The following is a description of a gene set: studied in species Homo sapiens Genes up-regulated in U2OS cells (osteosarcoma) upon knockdown of HDAC3 by RNAi. from publication Senese S, Zaragoza K, Minardi S, Muradore I, Ronzoni S, Passafaro A, Bernard L, Draetta GF, Alcalay M, Seiser C, Chiocca S (PMID 17470557) Human Gene Set: SENESE_HDAC3_TARGETS_UP Posttranslational modifications of core histones are central to the regulation of gene expression. Histone deacetylases (HDACs) repress transcription by deacetylating histones, and class I HDACs have a crucial role in mouse, Xenopus laevis, zebra fish, and Caenorhabditis elegans development. The role of individual class I HDACs in tumor cell proliferation was investigated using RNA interference-mediated protein knockdown. We show here that in the absence of HDAC1 cells can arrest either at the G(1) phase of the cell cycle or at the G(2)/M transition, resulting in the loss of mitotic cells, cell growth inhibition, and an increase in the percentage of apoptotic cells. On the contrary, HDAC2 knockdown showed no effect on cell proliferation unless we concurrently knocked down HDAC1. Using gene expression profiling analysis, we found that inactivation of HDAC1 affected the transcription of specific target genes involved in proliferation and apoptosis. Furthermore, HDAC2 downregulation did not cause significant changes compared to control cells, while inactivation of HDAC1, HDAC1 plus HDAC2, or HDAC3 resulted in more distinct clusters. Loss of these HDACs might impair cell cycle progression by affecting not only the transcription of specific target genes but also other biological processes. Our data support the idea that a drug targeting specific HDACs could be highly beneficial in the treatment of cancer., and this is the list of marker genes: KLF3 (KLF transcription factor 3), ZNF644, PAPOLA, PKIA, NAV3, SKIC3 (NCBI Gene Id 9652), INPP5A, ADAM19, NNMT, SINHCAF, KLRC1, DOCK4, PMAIP1, TALAM1, KHDRBS3 (NCBI Gene Id 10656), SHISA2, IDS, ITGA6, TGFBR1 (transforming growth factor beta receptor 1), PCDHB15, AADAC, CNTNAP3, IFI16, CXCL8, MAP3K2, STEAP3, DHX9, HHIP, TOP1, ESYT2, SYTL5, F2RL1, CPEB2, RAB35, BMAL2, KDM1B, ZBTB20, GGA2, YWHAZ, TNKS2, MMP1, LTBP2, EMP1, VAMP3, NR4A2, CREM, SERINC3, NMRAL2P, RBAK, SH3YL1, CPEB4, USP32, SCARB2, UEVLD, NFKB2, IL7R, TPP1, CLCN5 (chloride voltage-gated channel 5), XKR4, AGO2, CCL2, OASL, IL1RAP, SLFN5, UBE2F, USP53, FXR1, GPR176, GPHN, MEX3C, SPANXB1, SEC61A1, CXCL5, KBTBD2, TNIK, PDP1, ANTXR2, HTRA1, ZNF480, DLGAP1-AS2, MBNL2, SZRD1, BDP1, MMP9, STMN2, TUBA1A, CANT1, TNFRSF10B, PPFIBP1 (PPFIA binding protein 1), TFAM, DDX3X, CHRNA9, BTG1, USP16, OTUB2, MAP2, CXCL10, ZBTB38, ATP6V1A, E2F7, PHLDB2, GEMIN8, TGFBR2, PRDM1, STX16, FBXW11, ARL4C, VEGFC, CAMK2D, GSK3B, IFIT2, CD46, SETD5, TM9SF4, MALAT1, IQGAP1, ARHGDIA, WDR6, TNFSF15 (NCBI Gene Id 9966), EXOC5, TMEM30A, MOSPD1, PLEKHH2, TAOK1, ADAM10, ZNF92, EXTL3, KYNU, PGM2L1, NREP, SPRED1, PDLIM4, IGF2R, ERRFI1, MCL1, ANKRD46, ITGB3, PTPRR, STIP1, SOD2 (superoxide dismutase 2), PDGFC, AP1S3, GEM, IL1RAPL1 (NCBI Gene Id 4399), TM4SF18, HMGA2, IGF2BP3, MSC-AS1, CASK, SCD, ARHGAP5, RBM14 (RNA binding motif protein 14), PARP8, DPYSL3, BICD2, EFNA1, SNAP23, TSGA10, PPP3CA, MAPK14, CD55, SNHG16, ZNF451, BRCC3, AKT3, STING1, MCM4, EPRS1, TNFRSF11B, ANXA4, TEAD1, SNAPC3, MET, ASPH, CCND2, SLC7A1, IGFBP5, ACOX2, NBPF14, FMNL2, AFF4, TBC1D9, JMJD1C, NFKBIA, IQGAP2, DST, CUL4B, SLC6A15, TRPM4, SPP1, EFHD2, OLFM1, AP1AR, VPS25, MIR3142HG, EDIL3, ROBO4, TBC1D4, STK4, NEDD4L, AKR1C1, UBE2QL1, NCEH1, ROR1, NDRG4, MYO6, E2F5, PRR4, GFER, KLHL28 (kelch like family member 28), NAP1L1, SLC14A1, DCBLD1, CHD4, SLAIN2, HMGA1, CMTM7, LPIN1, KMT5AP1, SMARCC1, RDUR, HSF1, PI3, TMEM259, RGS4, SKP2, NEFL, MBNL1, HOXB6, KLF6, CXCL3, AKR1C3, TRIB1, FUS, FAS, CDKAL1, RNF19A, CALM3, PPP4R3A, PIP5K1A, CDKN1C, CTSB, ATP2B1, GRB10, PDK4, RSPO3, FOXC1, PIK3IP1, SPTBN1, KRT6B, ZNF317, RAB43, SFRP1, GFPT2, TMED2, RANBP2, TMEM158, RB1, UBASH3B, SCAMP1, SLC12A8 (solute carrier family 12 member 8), SAV1, GNG12, DNAJC13, MYO1B (NCBI Gene Id 92451), STYX, IFIT1 (NCBI Gene Id 8374), ABCC4, PLAU, TNFAIP3, SERPINE2, CCDC148, HDAC9, STX1A, LINC00161, NFAT5, ACTR2, ATP11B, NR6A1 (NCBI Gene Id 2649), PDE4B, FZD8, ZMAT3 (NCBI Gene Id 64393), MAPKAP1, NFKBIZ, SPANXA1 (NCBI Gene Id 93488), JAK1, GNG2, HSPA4, RHOB, OGDH, RAB8B, GCNA, ARL14, ASH1L, NUP58, EZR, AKT1S1, RBBP9, ESM1, LPXN, PMP22, PTPN11, BIRC3, WEE1, MIER3, HEATR1, ATF3, NEAT1, CCDC88A, NAMPT, SLC25A15, GCH1, HYCC1, WAC, IL6ST, ITGB8, NFYA, CEP170, ADAMTSL1, ENC1, SLC39A6, LINC00520, TLR4, PAPPA, GNA13, HAS2, CLDN12, MEAK7, CEP120, OPN3, ARSJ, USP10, MAML3, FAT3, ZNF41, IGKV1OR1-1, SUPT16H, PRKACB, KITLG, EIF4G1 (eukaryotic translation initiation factor 4 gamma 1), ARFIP1, STK10, SPIRE1, ZNF697, ENSG00000254531, DUS3L, TRIO, GTF2I, SCYL2, HNMT, SMG7, FAM9B, TAB3 (TGF-beta activated kinase 1 (MAP3K7) binding protein 3), AP1S1, RNF6, PRPF6, CBFB, ABCA3, TRAPPC10, BCL6, AKIRIN1, GTDC1, CDK17, KLHL24, MXRA7, TMOD3, RFX3, GALC, PTPRB, PTX3, CXADR, SRD5A1, ITPRID2, IL24 (interleukin 24), BMP2 (bone morphogenetic protein 2), ENHO, SAA1, GLYR1 (NCBI Gene Id 84656), SUPT6H, USP34, KCNMA1, HSP90AB1, TRAF1, SERPINB4, TM4SF1, HIVEP2, KDM7A, PLD1, MAN1A1, MAPK8IP1, SLC2A3, LEPR, CDV3, SLC16A1, SRPX, TMEM154, CDK6, OTUD4, TPR, BMP5, LMAN1, MTAP, MIPEP, PLCXD1, MAP3K4-AS1, BCL2L1, SLC12A4, LURAP1L, RGS16, POMGNT1, DUSP16, SLC25A37, IFIT3, BTG2, CCL20, AHCTF1, MT-ND5, ETS2, ENSG00000290941, GALNT12 (polypeptide N-acetylgalactosaminyltransferase 12), PCNX4, SLC7A11, NPAS2, DDX42, METTL16, SMAD5, ADGRL3, GLS, CD180 (CD180 molecule), MMP14, SQSTM1, ARF3, ADAM12, ORMDL1, TIMP3, B4GALT1, CALB1, HAPLN1, MICAL2, ARL6IP1, GASK1B, CYB5R2, GM2A, DCP2, ZC3H11A, SEPTIN11, LOX, SMG1, AKR1B10, TASOR2, ERVK13-1, APH1A (NCBI Gene Id 82089), NF1, ATP13A3, IL32, C6orf15, COPA, SPRED2 (sprouty related EVH1 domain containing 2), PPTC7, RPAP3, TFRC, MMP16, SLC6A6, PTBP3, WSB1, ELK3 (NCBI Gene Id 2004), PLEKHB2, MIR100HG, PTPN12, NXT2, SF3B1, DEPP1, TCN1, BACH1, FLOT1, PHTF2, UHMK1, ILRUN, TRPM8, GUCY1A2, SAT1, KAT6A, MAN1A2, CD44, G3BP2, PSME4, LINC01118, FCHO2, C16orf46, CDC27, RHOC, STRN, CREBRF, DNAJB14, FN1